Given this list of marker genes Ampd2, Adss1, Ampd1, Ppat, Urad, Gart, Xdh, Ada, Nt5c1a, Ampd3, Gmpr2, Paics, Atic, Urah, Hprt1, Nt5c2, Pnp, Nt5c, Aprt, Adss2, Adsl, Gmpr, Pfas, Uox, here is a description of the gene set: The chemical reactions and pathways involving IMP, inosine monophosphate. species: Mus musculus Mouse Gene Set: GOBP_IMP_METABOLIC_PROCESS